Given this list of marker genes MECP2, FMO3, HTT, SLC2A3, ZFX, here is a description of the gene set: species: Homo sapiens An aversive emotional state characterized by negative emotional experiences, preoccupations, or internal states that are often related to negative perceptions of the self, the world, or the future. Human Gene Set: HP_ABNORMAL_NEGATIVE_EMOTIONAL_STATE Abnormal negative emotional state